Given this list of marker genes CALM1, PPP3CB, FZD2, GNB3, PRKCA, AGO1, GNG8, PDE6B, TNRC6A, GNGT1, GNB1, TNRC6C, GNAO1, GNG7, GNG13, WNT5A, MOV10, AGO4, WNT11, PRKG1, PRKG2, GNG3 (G protein subunit gamma 3), MAP3K7, FZD6, CAMK2A, FZD5, PLCB2, GNG10, PDE6G, PLCB3, NLK, GNB4, ITPR1, PLCB1, PPP3CA, KRAS, TCF7L1, GNAT2, TCF7L2, LEF1, ITPR3, GNG5, CTNNB1, GNG11, GNGT2, GNG2 (G protein subunit gamma 2), FZD4, FZD3, PDE6A, GNG4, GNB5, PPP3R1, GNB2, GNG12, MYC, TNRC6B, AXIN2, AGO3, TCF7, NFATC1, AGO2, ITPR2, here is a description of the gene set: Human Gene Set: REACTOME_CA2_PATHWAY species: Homo sapiens Ca2+ pathway